Given this list of marker genes Alyreffm17, Igsf3, Amigo1, Nrg3, Zbtb41, Ramac, Tnks2, Ppp1r14c, Slc12a5, Dlc1, Trip12, Cebpg, Wdr26, Asxl1, Ptprj, Ssbp1, Lonrf1, Vangl2, Ccdc85a, Ccdc127, Csnk1g3, Psd4, Cxxc4 (NCBI Gene Id 83381), Cemip2, Cdc73, Tnfsf10, Snrk, Mosmo, F11r, Ugt8a, Chst15, Gpr20, Klhl2, Kit, Dusp22, Coa7, Ccser1, Pias1, Atg10, Lmo7, Eef2k (eukaryotic elongation factor-2 kinase), Ints8, Lrp8, Epb41l5, Lats2, Rnf152, H2bc24, Pard6b, Zfp185, Rcan2, Rapgef3, Crkl, Rasal2, Tmem121b, Sde2, Tpte, Stag1, Nfyc, Usp44, Fbxl17, Tgfb2, Macf1, P2ry1, Prkaa2, Dlg5, Zbtb42, Mms22l, Bag5, Magt1, Kctd11, Spta1, Rab8b, Ppm1a, Mcam, Slc66a2, Lpar2, Mtpn, Lcorl, Fnbp1, Aldh3a2, Mef2c, Gtf3c4, Hrk, Zfp532, Bsn, Trp53bp1, Arl4c, Ppm1h, Gpr63, Arhgap23, Wdr59, Atosb, Rmi1, Ift88, Tal1, Col8a1, Il15ra, Fosl2, Nsd3, Bbc3, Chmp3, Zcchc9, Zfp827, Slc4a4, Kif3c (NCBI Gene Id 16570), Fbxo45, Pard3b, Fbxw11, Gca, Thg1l, Ermp1, Mas1, Satb2, Pgap1, Bmerb1, Rictor, St3gal5, Mob3c, Ubap2, Pou3f2, Lgi2, Gnb4, Bmp5, Arl6ip1, Higd1a, Arhgap12, Hlf, Zbtb18, E2f1, Lin28b, Mbtps2, Zfp811, Anln, Foxp1, Six4, Tnfrsf1b, Tmco1, Bend4, Ung, Prtg, Pitpnm3, Rnf187, Creb1, Pi15, Nop16, Ccn4, Zxdb, Aff3, Ephb3, Zbtb34, Rad51d (RAD51 paralog D), Senp7, Wbp1l, Cd3d, Jarid2, Sytl4, Zzz3, Krtap4-9, Spock2, Coq8a, Pgbd1, Vax2, Prkg1, Ano4, Gli3, Pcsk2, Zfp46, Ilrun, Fthl17c, Plekhg1, Prdm16, Tmtc3, Il11ra1, Fam184a, Med13, Sort1 (NCBI Gene Id 99747), Rhbdl3, Ddx21, Slf2, Gphn, Zfp689, Ap1m2, Fam210a, Kif21b, Usp31, Tedc1, Frs2, Mcph1, A630001G21Rik, Fam204a, Fgf5 (NCBI Gene Id 14176), Asph, Fndc3b, Ptprb, Trib1, Pnma8b, Ptpn9, Dusp18, Foxo1, Ikbkb, Epha4, Zfp9, Igsf9, Yme1l1, Bclaf1, Gpr157, Tubal3, Prkag2, Serpinb8, Decr1, Dnajb6, Exoc5, Obi1, R3hdm4, Slc43a2, Rcbtb1, Fam107a, Cds2 (NCBI Gene Id 99122), Taok1, Chrna1, Nrp2, Ptbp3, Maml2, Tmed2, Pde7a, Vapb, Mef2a, Prr5, Mmp20, Pbx1, Ulk3, Mylk, Ugt2b35, Styk1, Rho, Rcbtb2, Msr1, Bcl2l15 (NCBI Gene Id 229672), Serpina1a, Sugp2, Cntn2, Metap1, Itgam, Adgra1 (adhesion G protein-coupled receptor A1), Ctbp2, Hdac7, Rbm20, Alyreffm11, Gtf2h5, Kdm4a, Dnajb1, Cnr1, Ogfod1, Pcdh9, Paqr7, Tlr4, Rnmt, Uqcc1, Gm57858, Ubr3, Zfp712, Brd10, Sbno1, Zfp462, Il18r1, Siah1a, Slc1a3, Pcdh10, Trpc6, Tnfrsf11a, Msx2, Bmp2, Arhgap11a, Mill1, Pacs2, Hecw1, Wdr73, Pde3a, Dlgap4, Fam227a, Card10, Akap9, Rap2b, Diras1, Atf1, Dzip3, Tc2n, Nras, Dpysl2, Tmem8b, Pik3ca, Elavl4, Tmem220, H2bc23, Clec7a, Siah1b, Pak6, Mgat4a, Dsel, Csmd1, Orai1, Ptprk, Wfdc12, Prdm1, Cstf3, Cisd2, Chek1, Phactr2, Crim1, Slc25a16, Cdc7, 2310022A10Rik, Agpat4, Kif1b (kinesin family member 1B), St8sia1, Srp72, Tent5a, E2f3, Fhod1 (NCBI Gene Id 234686), Pten, Akap8, Slc31a1, Egr3, Arl15, Mecom, Dnajc18, Ptp4a2, Kif3a, Stxbp6, Tcf15, Arrb1, Ubac1, Dnajb9, Ppp1r26, Gja5, Dtna, Klhl21, Tmprss13, Erc1, Ralgps1, Nmrk1, Akna, Nif3l1, Abhd18, Ahr, Bcl2l11, Sema4f, Map3k7, Grik3, Arhgef9, Cacna1c, Inpp5a, Cul4a, Ermap, Kcna2, Msl1, Kcna4, Dido1, Sh3gl2, Tppp, Ido2, Unc80, Cadm3, Alyreffm15, Pid1, Klhl24, Zfp516, Mast4, Dsc3, Cxcl15, Orc3, Nup133, Ppp2r2c, Nceh1, Nrarp, Ptges, Smarca4, Stx16, Ankle1, Sptbn1 (spectrin beta, non-erythrocytic 1), Nav2, Ptprt, Ythdc1, Gdi1, Nedd4l, Ilf3, Pdlim5, Kcnq2, Pyurf, Atf7, Ctif, Zfp174, Tbc1d30, Rabgap1, Prkca, Vwde, Ubn2, Abca14, F2rl1, Ephb1, Plpp1, Gxylt2, Cyp19a1, Dcx, Socs6, Osbpl8, Neurl1b, Tmem88b, Ddx5, Prr14l, Il22ra1, Alyreffm13, Slc10a5, Etv3, Nfe2l3, Clasp1, Igf1r, Adm, Parn, Manea, Xpo7, Cops7b, Ehmt1, Akap11, Zfp354a, Slc28a3, Mcf2l (NCBI Gene Id 338499), Hipk1, Cbln3, Coq10b, Fam120c, Elmo1, Synj1, Lrrc58, Sf3b1, Rasgrp1, Lhfpl4, Prr3, Rnf41, Cdh6, Ran, Efhd2, Slc40a1, Rbp3, Prkcd, Prkx, Flt4, Kcnmb1, Fign, Usp27x, Rsbn1l, Fzd5, Znrf3, Il21r, Snap91, Fthl17b, Ralgapa2, Slc25a46, Zfp808, Slc8a3, Cd1d1, Klhl9, Arid4a, Madd, Fthl17e, Kcnc1, Ncam2, Pakap, Rmi2, Nphs1, Pabpc4l, Sv2a, Araf, Sgcd, Dcaf12, Gm4791, Ndufs2, Phf21a, Amacr, Ssr1, Nek7, Tfcp2l1, Acvr1, Gabrb2, Acot11, Ecm2, Lgals3 (NCBI Gene Id 16854), Agtrap, Baiap2, Ankrd33b (NCBI Gene Id 70678), Rdx, Rsf1 (remodeling and spacing factor 1), Rraga, Yipf6, Cpne3, S1pr3, Cep97, Zbtb46, Adam2, Cdip1, Frmpd4, Blcap, Ptbp1, Rflnb, Bloc1s6, Mysm1, Ppp2r1a, Crebl2, Cxadr (NCBI Gene Id 70446), Plekha1, Rap1b, Ms4a4a, Specc1, Il1rn, Tspan2, Kcnj5, Usf2, Hif3a, Med27, Cry2, Arhgef10, Nfat5, Abca6, Get1, C2cd5, Ssbp2, Zbtb7a, C2cd4c, Ikzf2, Prl7a1, Mapk14, Msrb3, Slc39a14, Ripply3, Src, A130010J15Rik, Nexmif, D630045J12Rik, Crebzf, B3gnt2, Akap5, Igdcc4, Mllt6, Cytip, Tmem35a, Usp40, Slc12a2, Rora, Arl5b (NCBI Gene Id 99340), Lonrf3, Reep4, Casz1, Rtf1, Cntn3, Hectd2, Adamts2, Rnaseh2a, Lsm14a (LSM14A mRNA processing body assembly factor), Elovl7, Ccdc92b, Sel1l, Hapstr1, Junb, Zxdc, Grin2b, Paxbp1, Pdp2, Pea15a, Ss18l1, Zfx, Cdk19, Limd1, Smad2, Tgs1, Tmem239, Nav1 (NCBI Gene Id 408054), Ctsl (NCBI Gene Id 320361), Dyrk1a (dual-specificity tyrosine phosphorylation regulated kinase 1a), Tub, Mgat4c, Jakmip3, Trem6l, Muc15, Tpgs2, Slc4a7, Itsn1, Timm29, Pcdh15, Slc6a6, Rab6b, Zfp438, Pigc, Bmpr2, Tet1, Il17ra, Olr1, Mdga1, Srgap2, Gpd1l, Plet1, Hk2, Cadm2, Celsr2, Slc39a2, Wdcp (WD repeat and coiled coil containing), Tceal8, Zfp52, Nfatc4, Zmynd8, Trub1, Mrps24 (mitochondrial ribosomal protein S24), Vat1, Xrn1, Timm10, Creb5, Net1, Kcnb1, Tigit, Nhlrc4, Nudt18, Pfkfb2, Pik3r1, Dcbld2, Dsg2, Uqcrc2, Zcchc24, Shb, Nacc2, Slc25a51, Dcaf17 (NCBI Gene Id 98971), Lrp2bp, Otog, Baz2b, Foxk1, Zfp280c, Sat1, Grap2, Daam1, Smad7, Chic1, Adamts6, Mlx, Dennd6a, Gas7, Rasgrf2, Semp2l1, Tpcn1, Klra2, 1700028K03Rik, Septin3, Mrpl39, Zscan4d (zinc finger and SCAN domain containing 4D), Atxn7, Scn9a, Rnf38, Tmem201, Exosc9, Zscan4c, Acvr1b, Ogfrl1, Ptchd4, Oprk1, Sgsh, Wdfy3, Tbc1d16, Nasp, Cdk6, Casd1, Ssh2, Enah, Sgms1, AW554918, Ap2s1, Rgl1, Mrpl35, Eif2s1, Tril, Csnk2a1, Fbxl14, Ccp110, Unc5a, Tdrd1, Nvl, Nme7, Tyw1, Rab3ip, Pld2, Prmt8, Skint7, L2hgdh, Ypel2, Rap2a, Cog7, Adamts4, Foxf2, Kif2a, Dhx36, Hoxa5, Adcyap1r1, 1110059E24Rik, Topbp1, Bahcc1, Sim2, 5730409E04Rik, Tram1l1, Cdk12, Oxa1l, Itih5, Azi2, N4bp2l2, Smarcc1, Diaph2, Csmd2, Slc16a10, Mfsd2a, Cntnap2, Cmklr1, Pdk4, Bcl9, Plpp3, Kcnj10, Trp53inp2, Gmeb1, Tcf3, Rtn4r, Armc2, Ptbp2, Chd7, Mtf2, Mcts2, Igf1, Iqsec3, Rwdd4a, Ccdc25, Neo1, Rad51c, Fam53c, Midn, Scn8a, Mast3, Fam168b, Zfp618, Qsox2, Srek1, Zbtb10, Ndrg2, Ccdc92, Wipf2, Itgb6, Emc1, Armcx2, Ankrd24, Tns3, Ctsc, Klk10, Fam234b, Pot1a, Tll1, Diras2, Itgb3, Capza1, Shroom3, Smco4, Zfp26, Sox5, Insr, Zfp467, Ppargc1a, Fhip2a, Mfap1a, Zdhhc21, Rnf214, Rnf19b, Tulp3, Alyreffm16, Eif4e2, Fbn1, Sypl1, Kdm7a, Tbck, Ppp1r3b, Usp46, Amtn, Coa5 (cytochrome C oxidase assembly factor 5), Sema6d, Mmp12, Larp1, Slc6a17, Shisal1, Ube4a, Fkbp6, Asb7, Errfi1, Gtpbp1, Epha5, Slc7a2 (NCBI Gene Id 11988), Usp5, Nsd1, Ywhaq, Gpr173, Hoxc10, Rps6ka3, Csnk1d (NCBI Gene Id 71708), Npy1r, Smarcad1, Tmc7, Or5d38, Dgkq, Usp15, Hook3, Slc6a8, Grb2, Zbtb7b, Stxbp5l (syntaxin binding protein 5-like, NCBI Gene Id 207227), Phip, Arl6ip6, Ncbp3, Ptgfrn, Pclaf, Prrg3, Foxn1, Bcor, Cep350, Snapc1, Cacna2d2, Ap1g1, Tbx20, Cyld (NCBI Gene Id 74256), Gm14137, Fgf14, Btf3l4, Ttbk2, Fjx1, Tcte1, Rgs20 (NCBI Gene Id 80621), Gad2, Scrt2, Slx1b, Ep300, Oas3, Spag7, Tas1r3 (taste receptor, type 1, member 3), Ino80d (NCBI Gene Id 329170), Ash1l, Rmnd5a, Ewsr1, Tbl1xr1, Jag2, Vav3, Ankrd44, Prn, Rbm33, Ifit3b (NCBI Gene Id 667370), Spsb4, Naaa, Klf6, Mapk10, Tet2, Tacr2, Csnk1a1, Synj2bp, Sec14l1, Ifit3, Itpripl2 (NCBI Gene Id 330636), Galnt2, Nfxl1, Ptprc, Mlxip, Ms4a4c, Zfp963, Sema4b, Lrrc3, Elovl5, Synrg, Cast, Amot, Golga7b, Luc7l2, Ccl28 (NCBI Gene Id 56838), Trim44, Atxn1 (ataxin 1), Igfbp4, Med1, Prnd, Trim67, Col25a1, AI429214, Akap10, Ccdc138, Twf1, Unc5b, Kmt2d, Clcn6, Kif5a, Ldlrad3, Nrf1, Ipo5, Apobec3, Homer2, Ttc23, Lmx1a, Rapgefl1, Tbx4, Fzd4, Rbm18, Pank3, Atp1b3, Car8, Zfp157, Rgs8, Tmem108, Chmp1b2, Zfp839, Mapk1ip1l, Usf3, Camkk2, Mrap2, Fat3, Atf2, Hnrnpd, Smad6, Syt7 (NCBI Gene Id 78663), Zfp871, Chd5, Plekhg3, Nudcd3, Gfod1, Ago2, Cnot7, Saa1, Cuedc1, Uri1, Wfs1, Cep170b, Klhl31, Stx1b, Armc8, Rai1, Klf14, Dpysl5, Gm6377, Prkab2, Alyreffm10, Lfng, Pcgf2, Nemp2, Nbeal1, Tnrc6b, Zdhhc24, Igsf9b, Kcnc4, Rsad2, Ercc6, Htr2b, Plcl1, Rab3c, Zfp281, Gripap1, Scamp1, Taf7l, Prss22, Rasgrp3, Ubxn2b, Bmi1, Gda, Pappa, Klf11, Mtfr2, Hic2, D16Ertd472e, Phf3 (NCBI Gene Id 98560), Raph1, Maged1, Pdzd4, Syt2, Sema4c, Tcf4, Tmppe, Psd3, Arf3, Tmem170b, Il11ra2, Dusp2, Rnasel, Rad54l2, Dph3, Iglon5, Sdad1, Mapre1, En2, Taf4b (TATA-box binding protein associated factor 4b), Xrcc4, Pbld2, Zfp286, Rpp40, Zfp169, Scg2, Zfhx3, Aak1, Fem1b, Map3k2, Meis2, Ffar3, Zswim5, Btnl9, Mettl27, Tmem196 (transmembrane protein 196), D630023F18Rik, Pfn1, Tasp1, Csrnp3, Tbc1d13, Slfn5, Trak1, Kdm5a, Plag1, Zfp791, Them4, Mgam, Sh3pxd2a, Itpk1, Serac1, Fzd3, Dnajc19, Mat2b (NCBI Gene Id 68881), Foxn3, Wdr89, Gpr50, Tmprss11b, Marveld3, Stk3, Arnt, Dnajb4, Ston2, Brd8, Lnpk, Slc11a2, Utp14a, Mfsd4b5, Zdhhc3, Gpr146, Zfhx4, Pde1a, Tnpo1, Wwp2, Nup50 (NCBI Gene Id 69508), Synpo2l, Il11ra3, Bicd1, Cdk5rap2, Mpp2, Pkib, Vamp2, Dhx40, Zbtb39, Pcdh11x, Lrig2, Atp10a, Plxna4, Spata13, Prrg4, Lypd1, Myadm, Adamts18, Kif13a, Slc2a10, Tmem101, Cckar, Nr2c2, Pign, Sh3kbp1, Lias, Alyreffm14, Herc6, Fndc3a, Tbpl1, Plscr4, Kctd12, Hnrnpll, Fhip2b, Hdac9, Zbtb4, Pak4, Mxi1, Hif1an, Klhl23, Pck1, Cpne8, AI987944, Ccdc169, Pon2, Sdcbp, Ppm1d, Ptpn3, Ezh1, N4bp1, Pes1, Ppp1r2, Gpr180, Phaf1, Mmab, Ets1, Vegfa, Ubtf, Mef2d, Ms4a6d, Psme3, Rnf157, Ap3d1, Fbxo38, Tbc1d15, Soat1, Hemgn, Alkbh1, Dcaf5, Zdbf2, Desi2, Tmem65, Or12j5, Aff4, Col9a1, Nog, Ids (iduronate 2-sulfatase), Mlxipl, Dennd5b, Foxj3, Plau, Tmem179, Glcci1, Leng8, Slc35a2, Loxl3, Foxa1, Irs4, Scml4, Fryl, Nkx1-2, Mon2, 2310033P09Rik, Mcemp1, Snx30, Cdc14a, Npas3, Naa15, Rassf10, Tcf7l1, Dusp9, Slc8a1, Hs3st3b1, Ptpmt1, Usp13, Nup93, Rsad1, Gmps, Ddit4l, Vps13d, Steap2, Mblac2 (metallo-beta-lactamase domain containing 2), Gin1, Fbxo32, Ralgps2, Ebf2, Adam19, Kif27, Tnfrsf9, Gsk3b, Pms2, Cfap126, Nr1d2, Lbh, Septin12, Slc25a37, Krit1, Zc2hc1a, Grik2, Selenot, Slc16a7, Nfatc2, Nectin4, Zfp408, AU018091, Tmem178b, Btla, Fam78b, Ube2ql1, Slc10a2, Ints6, Slc36a1, Arhgap6, Rnf217, Lrpprc, Zfp1008, Cers6, Slc7a11, Denr, Prkaa1, Arhgap26, Fras1, Fam219a, Eya1, Slc5a3, Trp53inp1, Adcy6, Atf7ip, Bub1, Cyb5r2, Srcin1, Amotl1, Pdpk1, Lasp1, Sin3a, Mtfmt, Dtl, Mob1b, Col13a1, Macc1, Fam131a (NCBI Gene Id 78408), Szrd1, Zc3hav1l, Ephx3, Dip2b, Skil, Ms4a6b, Lacc1, Nip7, Il17rd, G3bp2, Plxnc1 (NCBI Gene Id 80638), 9530068E07Rik, Irgq (NCBI Gene Id 210146), Hhip, Mllt3, Csrnp1, Zbtb25, Ubr4, Gxylt1, Ctdp1, Cyb5r1, Tent4b, Ehf, Rgmb, Optn, Eif1ad, 2900026A02Rik, Ccng2, Marf1, Ric8b, Atl2, Frat2, Atm, Enpp4, Insig2, Xpo1, Vapa (vesicle-associated membrane protein, associated protein A), Adcy9, Evc2, Bcl11b, Prps2, Piga, Dzank1, Ldb3, Inka2, Mis12, Adcy1, Dipk1c, Trim25, Tlk2, Kcnj12, Nab1, Pttg1, Zfp663, Otulinl, Rab1a, Pheta2, Cep76, Sec22a, Mtx3, Stxbp2, Eaf1, Slc17a8, Vstm2a, Fbxo31, Srp68, Ppm1f, Nufip2, Klf13, Sp110, Adamts9, Med28, Zmat2, Donson (NCBI Gene Id 68649), Cfap68, Trhde, Pkp1, Slc41a3, Myog, Tmed8, Ackr4, Bach2, Zmynd11, Slc35a1, Slc6a2, Depdc5, Esm1, Kcmf1, Npbwr1, Tmem151b, 3110082I17Rik, Dffa, Tead1, Tmem252, Slco5a1, Utp23, Trmt61a, Ube2v2, Suv39h2, Wnt5a, Pax3, Frmd3, Alkbh5, Haus2, Arhgef15, St8sia4, Clic5, Dgcr2, Llgl1, Nus1, Lrrc10b, Sfn (stratifin), Api5, Dclk1, Arl14epl (NCBI Gene Id 381142), Cacna1b (NCBI Gene Id 99436), Btn1a1, Bpifc, Hlcs, Tbc1d22b, Ovca2, Arid1b, Spx, Zc3h7b (zinc finger CCCH type containing 7B), Arhgef18, Hivep3, Ubxn7 (UBX domain protein 7), Dusp6, Zdhhc7 (NCBI Gene Id 102193), Unc5c, Ociad2, Zc3h12d, Xpot, Phtf2, Nbea, Plekha2, Slc1a2, Nectin1, Fus, here is a description of the gene set: Genes predicted to be targets of miRBase v22 microRNA mmu_miR_669c_3p in miRDB v6.0 with MirTarget v4 prediction scores > 80 (high confidence targets). from publication Chen Y, Wang X (PMID 31504780) Mouse Gene Set: MIR_669C_3P species: Mus musculus